Given this list of marker genes Cyp2c55, Cyp2c50, Cyp2j8, Cyp2j6, Cyp2j13 (cytochrome P450, family 2, subfamily j, polypeptide 13), Cyp2j9, Cyp2j11, Cyp2j7, Cyp2j12, Cyp2j5, Cyp2c54, here is a description of the gene set: Mouse Gene Set: GOMF_LINOLEIC_ACID_EPOXYGENASE_ACTIVITY studied in species Mus musculus Catalysis of an NADPH- and oxygen-dependent reaction that converts linoleic acid to a cis-epoxyoctadecenoic acid.